Given this list of marker genes HTR1F, OR2A20P, TAAR3P, CELSR3, ADRB2, EDNRA (endothelin receptor type A), HTR2A, MCHR2, OR8G1, CELSR2, S1PR1, GRM8, GRM1, GHRHR, CHRM2, VN1R1, OR2A5, TAAR5, OR2B6, OR6C2, DRD4, ADGRG1, SMO, OR3A3, GPR83, OR1E1, GPR176, RXFP1, NTSR1, PROKR2, GPR55, GPR143, UTS2R (urotensin 2 receptor), CXCR1, CNR1, GPR84, GPR88, ADORA3, F2R (coagulation factor II thrombin receptor), OR10A2, P2RY13, CXCR3, GRPR, OR2A4, OR10A5, GNRHR, ADORA2A, OR7E24, OR7A17, HRH4, CCKBR, ADGRF5, RXFP3, OR2H1, LGR6, ADGRE3, GPR183, GPR61 (G protein-coupled receptor 61), GPR62, CCR5, OR2M4, FSHR, HTR7, GPR162, ACKR1, ALG6, ADRA1D, TAAR2, GPR135, GPR18, P2RY11, OR2F1, SSTR2, OR5AC2, ADGRD1, GPR132, CHRM3, C5AR2, ADGRL2, CELSR1, GPR17, ADGRE2, DRD3, ADGRL3, OR1N1, CXCR2, PTGFR, OR6C3, LTB4R2, OR1G1, OR1F1, ADGRV1, OR3A1, here is a description of the gene set: studied in species Homo sapiens GPCRs, other Human Gene Set: WP_GPCRS_OTHER